Given this list of marker genes Kctd7, Cftr, Agt, Slc26a3, Kcnq3, Trpc5, Rbfox2 (NCBI Gene Id 93686), Kcna5, Kcnq2, Prkcz, Cacnb3, Hcn1, Crtc1, Kcnc2, Sod2, Atp1a1, Kcnj10, Cntf, Casp1, Cacng2, Park7, here is a description of the gene set: Mouse Gene Set: GOBP_MEMBRANE_HYPERPOLARIZATION species: Mus musculus The process in which membrane potential increases with respect to its steady-state potential, usually from negative potential to a more negative potential. For example, during the repolarization phase of an action potential the membrane potential often becomes more negative or hyperpolarized before returning to the steady-state resting potential.